Given this list of marker genes MMP19, FGF2, IL18, PTPRR, ANPEP, ANGPT1, TNFAIP2, PBX3, NRG1, JAG1, TNFSF12, DIO1, VEGFD, FGF1, EPAS1, CXCL8, here is a description of the gene set: species: Homo sapiens Human Gene Set: MODULE_516 Genes in the cancer module 516.